Given this list of marker genes NUP160, DDX20, GEMIN6, SNRPE, GEMIN5 (gem nuclear organelle associated protein 5), NUP58, SNRPD3, NUP43, NCBP2, NUP42, GEMIN4, SNRPG, SEH1L, GEMIN7, AAAS, POM121C, NUP93, NUP37 (NCBI Gene Id 79023), PHAX, POM121, NUP205, NCBP1, SEC13 (SEC13 homolog, nuclear pore and COPII coat complex component), SNRPD2, RANBP2, RAE1, TGS1, NUP88, SNRPB, WDR77, GEMIN2, NUP85, SNRPD1, NUP153, CLNS1A, NUP133, NUP188, NUP54, SMN2, NUP214, TPR, PRMT5 (protein arginine methyltransferase 5), GEMIN8, NUP50, NUP155, NUP62, NDC1, NUP35, SMN1, NUP107, NUP210, SNUPN, NUP98, SNRPF, here is a description of the gene set: species: Homo sapiens snRNP Assembly Human Gene Set: REACTOME_SNRNP_ASSEMBLY